The following is a description of a gene set: Tissue resident memory (Trm) represent a newly described memory T cell population. We have previously characterized a population of Trm that persists within the brain following acute virus infection. Although capable of providing marked protection against a subsequent local challenge, brain Trm do not undergo recall expansion following dissociation from the tissue. Furthermore, these Trm do not depend on the same survival factors as the circulating memory T cell pool as assessed either in vivo or in vitro. To gain greater insight into this population of cells we compared the gene-expression profiles of Trm isolated from the brain to circulating memory T cells isolated from the spleen following an acute virus infection. Trm displayed altered expression of genes involved in chemotaxis, expressed a distinct set of transcription factors and overexpressed several inhibitory receptors. Cumulatively, these data indicates that Trm are a distinct memory T cell population disconnected from the circulating memory T cell pool and displaying a unique molecular signature which likely results in optimal survival and function within their local environment. from publication Wakim LM, Woodward-Davis A, Liu R, Hu Y, Villadangos J, Smyth G, Bevan MJ (PMID 22922816) species: Homo sapiens Human Gene Set: GSE39152_CD103_NEG_VS_POS_MEMORY_CD8_TCELL_DN Genes down-regulated in memory CD8 T cells from brain: ITGAE- versus ITGAE+., and this is the list of marker genes: HOXD8, ELK3, DPF2, POLK (NCBI Gene Id 51426), C3orf38, TRAPPC3, ZIC3, ARHGEF2, IER3, HIPK3, TIMM10B, MAFB, SEC13, TBC1D15, STX12, DDX21, KCNAB1, GPS1, CCR3 (NCBI Gene Id 1232), EPHB2 (EPH receptor B2), MT2A, TCF20, TSPAN4, SOAT2, ANK1, ITPA, TIPARP, RPL7L1, ZFP36, TMEM50B, ARFIP2 (ADP ribosylation factor interacting protein 2), BCKDK (branched chain keto acid dehydrogenase kinase), PPA1, AHR, FBXW11, GLI3, G3BP2, GADD45G, PTRH2, ARPC3, GPN2, TIMP1, MRPL20, ASNS, CLPX, PEX11B, UBE2M, ARMCX2 (NCBI Gene Id 9823), IL18BP, CTSC, TLR6, ACOT8, IL4R, IFNAR1, KRTCAP2, TACR1, SNX5, PPP2R1A, ATP7A (NCBI Gene Id 613259), LTB4R, MZT2B, KCNJ8, EIF6, STAT3, TCERG1, ACSL1, KDR, CAND1, MYD88, MAP7, RCC1, ABCF2, HOXC8, RRBP1, ATP5MC1, CD3D, NOC4L, KPNA1, RAB3IL1, TMPRSS15, FCGR2B, ARF3, TENT5C, AMBP, MIDN (NCBI Gene Id 94034), TGFBI, NUBP1, PIAS1, JAK3, AQP9, C5AR1, SLC1A1, GPD2, CLIP3, CDKN2D, SOCS3, RHOA, TFF3, IARS1, SUSD6, AMOTL2, PAPOLA, HDAC1, CLPTM1L, ALKBH5, BAG3, RAMP3, B3GALT4, FABP5, FARSA, UQCC2, GCNT1, ZBTB2, SLC2A1, STOML2, SCAMP3, NCF1, DES, NDRG1, RDH13, TM2D2, NSMCE1, TXNRD1 (NCBI Gene Id 7296), ASAP1, ABCE1, CCT6A, MRPL34, ABCC1, UCK2, LPP, SAMD4B, GSPT1, PRX, PRDM1, KIAA1191 (NCBI Gene Id 80202), CCR5, SHF, SMARCC1, BMP2K, MEMO1 (NCBI Gene Id 63983), GALNT2, MUC1, SYNGR2, MYL7, PTPN1, AP1B1, ARNT, ANXA3, AIMP2, FURIN, EIF1B, CCL4, PIM1, SPART, EPS8, BCL2L1, ABCA1, DNAJC7, TCP10L, GNPTAB, PDZD11, TM4SF1, MDH2, RUNDC3A, TIMM17B (NCBI Gene Id 10245), KIF5C, GPR12, NFIL3, APBA3, EIF1AY, CENPB, PTPRN, NUPR1, ATP8A1, HLA-DQA1, FUT2, SLC3A2, STX5, PSMD3, RAB4B, AP1G1, UCP3, HCN1, CIC, SSR2 (signal sequence receptor subunit 2), NELFA, UBE2S, C6orf136, TRAPPC14, BSDC1, MASP2, HSD3B7, HMOX1, SMPD1, SLC12A7 (NCBI Gene Id 26129), PCLO (NCBI Gene Id 56630), BMP8B, NAT2, MPP3, SLC35B1